The following is a description of a gene set: Human Gene Set: HP_POOR_MOTOR_COORDINATION species: Homo sapiens Poor motor coordination, and this is the list of marker genes: MTRFR, KLHL41, DNAL4, NTN1, SNORD115-1, CUX1, POMT1, RTL1, GDAP1, NEB, FMR1, ATP7B, ADGRV1, PIEZO2 (NCBI Gene Id 63896), GABRA1, RAI1, DCC, FOCAD, SCN2A, FOXP2, ACTA1, DCX, CXCR4, MKRN3, SCN9A, GABRD, PWAR1, RDH11, SCN1A, CAMTA1, EBF3, DARS2, GCDH, TPM3, SLC2A3, RAD51, FKRP, HTT, POMT2, MEG3, PRNP, MYPN, BMPR1B, STX1B, VPS13A, DLK1, PMPCA, MFN2, SNORD116-1, BSCL2, GMPPB, DMPK, AASS, KBTBD13, FXN, PPP2R2B, KCNQ2, TPM2, LARGE1, SIN3A, NPAP1 (NCBI Gene Id 23742), MMACHC, HERC2, VCP, SBF2, PWRN1, GNB5, ZEB2, PDHX, SCN1B, GABRG2, HCN1, ALMS1, GNE, PRRT2, MAGEL2, FGF13, EZH2, THG1L, ATP9A, RNU12, PCDH19, SLC30A10